Given this list of marker genes Ngf, Ywhae, Casp2, Ngfr, Casp3, here is a description of the gene set: electronically inferred by orthology from the curated human pathway species: Mus musculus Reactome Pathway: NADE modulates death signalling This event has been computationally inferred from an event that has been demonstrated in another species.<p>The inference is based on the homology mapping from PANTHER. Briefly, reactions for which all involved PhysicalEntities (in input, output and catalyst) have a mapped orthologue/paralogue (for complexes at least 75% of components must have a mapping) are inferred to the other species. part of: Cell death signalling via NRAGE, NRIF and NADE